The following is a description of a gene set: studied in species Homo sapiens The mature form of urokinase plasminogen activator receptor (uPAR) is attached to the plasma membrane by a glycosylphosphatidylinositol (GPI) anchor. As nascent uPAR polypeptide moves into the lumen of the endoplasmic reticulum, it is attacked by a transamidase complex that cleaves the uPAR polypeptide after residue 305, releasing the carboxyterminal peptide of uPAR and replacing it with an acylated GPI moiety. In a second step, the GPI moiety is deacylated, yielding a uPAR-GPI conjugate that can be efficiently transported to the Golgi apparatus. part of: Post-translational modification: synthesis of GPI-anchored proteins Reactome Pathway: Attachment of GPI anchor to uPAR, and this is the list of marker genes: PIGT, PGAP1, PIGK, PLAUR, GPAA1, PIGS, PIGU